The following is a description of a gene set: Mouse Gene Set: REACTOME_SHC1_EVENTS_IN_ERBB4_SIGNALING studied in species Mus musculus SHC1 events in ERBB4 signaling, and this is the list of marker genes: Nrg3, Ereg, Hbegf, Shc1, Sos1, Erbb4, Btc, Grb2, Hras, Kras, Nrg1